Given this list of marker genes Rdh9, Isx, Rdh10, Rdh1, Rdh16f2, Akr1c18, Rdh16, Rdh19, Dgat1, Prmt3, here is a description of the gene set: Any process that modulates the frequency, rate or extent of the chemical reactions and pathways involving isoprenoids. studied in species Mus musculus Mouse Gene Set: GOBP_REGULATION_OF_ISOPRENOID_METABOLIC_PROCESS